The following is a description of a gene set: studied in species Mus musculus from publication Cui A, Huang T, Li S, Ma A, Pérez JL, Sander C, Keskin DB, Wu CJ, Fraenkel E, Hacohen N (PMID 38057668) Cytokines mediate cell-cell communication in the immune system and represent important therapeutic targets. A myriad of studies have highlighted their central role in immune function, yet we lack a global view of the cellular responses of each immune cell type to each cytokine. To address this gap, the authors created the Immune Dictionary, a compendium of single-cell transcriptomic profiles of more than 17 immune cell types in response to each of 86 cytokines (>1,400 cytokine-cell type combinations) in mouse lymph nodes in vivo. A cytokine-centric view of the dictionary revealed that most cytokines induce highly cell-type-specific responses. For example, the inflammatory cytokine interleukin-1β induces distinct gene programmes in almost every cell type. A cell-type-centric view of the dictionary identified more than 66 cytokine-driven cellular polarization states across immune cell types, including previously uncharacterized states such as an interleukin-18-induced polyfunctional natural killer cell state. Genes positively differentially expressed in cell type: pDC (plasmacytoid dendritic cell) upon treatment with cytokine: IL-27 in mouse lymph nodes in vivo. Mouse Gene Set: CUI_PDC_IL27_RESPONSE_UP, and this is the list of marker genes: Tgfb1, Irf7, Ifi27l2a, H2-Q6, Mzb1 (marginal zone B and B1 cell-specific protein 1), Cd4, Ly6a, Cd180, H2-T23, Ccdc162, Hsd11b1, H2-Q7